Given this list of marker genes DUSP2, ATP6V0C, FOSL2, MIR564, NKPD1, ZBED2, ENC1 (NCBI Gene Id 8507), ACBD3-AS1, MAP3K8, NT5C1B-RDH14, MIR22HG, NICOL1, LINC02870, PHLPP1, here is a description of the gene set: Systems biology is an approach to comprehensively study complex interactions within a biological system. Most published systems vaccinology studies have utilized whole blood or peripheral blood mononuclear cells (PBMC) to monitor the immune response after vaccination. Because human blood is comprised of multiple hematopoietic cell types, the potential for masking responses of under-represented cell populations is increased when analyzing whole blood or PBMC. To investigate the contribution of individual cell types to the immune response after vaccination, we established a rapid and efficient method to purify human T and B cells, natural killer (NK) cells, myeloid dendritic cells (mDC), monocytes, and neutrophils from fresh venous blood. Purified cells were fractionated and processed in a single day. RNA-Seq and quantitative shotgun proteomics were performed to determine expression profiles for each cell type prior to and after inactivated seasonal influenza vaccination. Our results show that transcriptomic and proteomic profiles generated from purified immune cells differ significantly from PBMC. Differential expression analysis for each immune cell type also shows unique transcriptomic and proteomic expression profiles as well as changing biological networks at early time points after vaccination. This cell type-specific information provides a more comprehensive approach to monitor vaccine responses. species: Homo sapiens from publication Hoek KL, Samir P, Howard LM, Niu X, Prasad N, Galassie A, Liu Q, Allos TM, Floyd KA, Guo Y, Shyr Y, Levy SE, Joyce S, Edwards KM, Link AJ (PMID 25706537) Human Gene Set: HOEK_T_CELL_2011_2012_TIV_ADULT_3DY_DN Genes down-regulated in T cell 3d vs 0d in adults after exposure to 2011-2012 trivalent inactivated vaccine (A/California/7/09 (H1N1), A/Perth /16/2009 (H3N2), B/Brisbane/60/2008), time point 3D. Comment: Down-regulated DE RNA transcripts (down >= 1.5x) shared between both TIV-vaccinated donors